The following is a description of a gene set: studied in species Homo sapiens Gentle upward curve of the upper lip vermilion such that the center is placed well superior to the commissures. Human Gene Set: HP_U_SHAPED_UPPER_LIP_VERMILION U-Shaped upper lip vermilion, and this is the list of marker genes: ZC4H2, ATRX, EHMT1, MAPK1, DPM1, RNU4-2, TAF4, CDK19, ZSWIM6